Given this list of marker genes UBC, WWP1, SRC, UBB, ERBB4, NEDD4, RPS27A (NCBI Gene Id 6233), ITCH, UBA52, here is a description of the gene set: Downregulation of ERBB4 signaling species: Homo sapiens Human Gene Set: REACTOME_DOWNREGULATION_OF_ERBB4_SIGNALING